Given this list of marker genes FN1, ITGB1, ITGA2, ITGA4, GIT2, CDC42, ITGB3, ITGA10, ITGB5, ITGA5, ITGA1, ITGA3, ITGB4, ARHGEF7, PTK2, ITGA11 (NCBI Gene Id 22801), ITGB6, ITGA7 (NCBI Gene Id 81988), ITGA2B, ITGA9, ITGB7, ITGA8, ITGB8, SRC, PXN, ITGAV, here is a description of the gene set: Human Gene Set: KEGG_MEDICUS_REFERENCE_ITGA_B_FAK_CDC42_SIGNALING_PATHWAY ITGA/B-FAK-CDC42 signaling pathway. Pathway ID: N01070. Pathway type: Reference. Pathway class: nt06135 Cytoskeletal regulation (viruses and bacteria). Pathway Definition from KEGG: FN1 -> (ITGA+ITGB) -> (SRC,PTK2) -> PXN -> (GIT2+ARHGEF7) -> CDC42 species: Homo sapiens